Given this list of marker genes CIT, PEX5, ACD, MAT1A, NDUFS1, ADPRS, CHP1, LYRM4, KCNJ18, NR4A2, PITX3 (NCBI Gene Id 5309), ATP5MK, ALG3, MAGEL2, KIDINS220, CAPRIN1, TRMT10A (NCBI Gene Id 93587), FXN, FOXG1, WDR73, TMX2 (NCBI Gene Id 51075), TSEN2, AAAS, ERLIN2, NUP54, MYPN, SBF2, GBE1, NDUFAF2, ZFR, OCA2, H4C5, SLC18A2, TAF13, DYNC1I2, CASK, TSHR, TLR4, PET100, CCDC88A, DES, IFRD1, COQ4, MECR, PLEKHG5, SYNE2, TARDBP, PEX1, HSPB1, CYP27A1, LBR, SLC1A3, SDHAF1, ADGRG1, CNTNAP2, YARS1, YWHAG, KIF1B, LETM1, AIFM1, PPP1R15B, GTF2IRD2, LHX3 (NCBI Gene Id 8022), PRX (NCBI Gene Id 57716), CAMSAP1, GLRB, FTH1, LIMK1, POU1F1, GCSH, ERCC5, FANCM, REEP1 (receptor accessory protein 1), SLC20A2, NDUFS4, ABCC9, NFASC, PMPCA, PEX14, FANCF, MED25 (mediator complex subunit 25), MT-TT, GLYCTK, KBTBD13, STAT4, COQ7, GLRX5, XPC, TMCO1, HESX1, TRIM32, GDAP2, CHCHD2, CHCHD10, FUS, TMEM106B, GABRA2, LGI3, XRCC1, CHAT, SLC5A5, ACTA1, CAMTA1, CPT1C, PEX26, FBXL4, RMND1, CHRNB1, DNASE1L3, TBC1D23, GBA1, UBE3A, PEX19 (NCBI Gene Id 7835), OCRL (NCBI Gene Id 4952), BAZ1B, FA2H, DCTN1, SNUPN, COQ2, CSF1R, CEP63, TOE1 (NCBI Gene Id 80147), TMEM63A, VLDLR, KCNMA1 (potassium calcium-activated channel subfamily M alpha 1), PYROXD1, PLOD1, NAGLU, FXR1, MT-TE, CDK19, PNPLA2, ITGA7, ELN, RTEL1, HRAS, PARS2, COL4A1, SCYL1, NT5C2, HMGCL (3-hydroxy-3-methylglutaryl-CoA lyase), WASHC5, AP4B1, FLRT1, AGTPBP1, NSRP1, TCEAL1, ANG, BCKDK, ERCC3, EYA1, RNF113A, MINPP1, POU4F1, HCN1, STUB1, TIMM8A, ACER3, COX8A (NCBI Gene Id 1351), MT-TK, BICD2, SARS1, SDHA, CDK5, VPS13D, MYH14, SPTBN4, VCP, SLC25A12, NOP56, GPT2, ADCY5, SCN4A, ESAM, KY, CEP135, MT-ND2, FANCE, FBXO38, ENTPD1 (ectonucleoside triphosphate diphosphohydrolase 1), NEK1, SLX4, DYNC1H1, HYCC1, GTPBP2, KRAS, DNM2, RLIM, SNAPC4, PUS3, CNKSR2, CHRNE, PI4KA, NUP37, SLC12A2, PANK2, PKDCC, UBQLN2, DNAJC6, DNMT1, PRSS12, SPG11, DBH, LRP4, NIPA1, FGD4, JPH3, IRF2BPL, MBOAT7, SCN1A, GIPC1, CEP152, CHRND, MSTO1, RNF220, TTC19, LIFR, KDM5C, DYSF, HNRNPK, MYF6, INF2, VWA3B, XK, PSMC1, MAP3K20, PEX7, ATP1A3, RAB18, EXOSC8, TRIM37, CAMLG, ACTL6B, PIGQ, HSPG2, ALG1, DPYD, SNIP1, SIGMAR1, HTT, OPA1, EMILIN1, MRPS34, TRAPPC11, HLA-B, SNAP25, SLC52A3, TREM2, METTL5, DDC, SPTBN2, PDHB, NDUFAF4 (NADH:ubiquinone oxidoreductase complex assembly factor 4), SLC16A2, ANXA11, EXOC8, HEXB, COX6A1, ATXN3, CASP2, PIGA, ELOVL1, RAPSN, MSTN, PPOX, GNAO1, APOE, LMOD3, GTF2H5, HUWE1, TSEN34, COX11, SCYL2, DHTKD1, MYO1H, ALG11, ATG5, STAC3, TMEM43, LARGE1, SCN11A, RFT1, CNP, LGI4, BSND, PDGFRB, TTBK2, POMT2, OBSCN, ANKLE2, HSPD1, KCNB1, NONO, GLRA1, FKBP6, SV2A, PEX12, SPAST, CTSF, WWOX, TGM6, NDUFS8, ATP6AP2, PIGN, GFER, WDR4, PIEZO2, NECAP1, PROP1, REPS1, NDUFS2, APTX, SCN8A, MT-CO3, TRAPPC10, CREBBP, PEX16, NUP62, MDH2, GJA1, EEF2, VAMP1, PRICKLE1, SPEG, SLC39A8, GMPPB, GRM1, DKC1, DARS2, PIGB, HTRA2 (NCBI Gene Id 27429), AGRN, MFF, SPTLC1, FKBP10, AARS1, NRCAM, FASTKD2, SLC35A1, CCDC88C, CCR1, PRKN, UBAP1, SLC25A1, TSHB, FANCD2, FANCI, NADK2, CHKA, KCNA1, TBCK, MAB21L1, NFU1 (NCBI Gene Id 80767), HPDL, CCNF, SLC31A1, BRIP1, MAN2B1, GNS, COL6A1, FDX2, HECTD4, NEFL (neurofilament light chain), NDUFA4, DHX9, NCF1, BCAS3, METTL27, POLG2 (NCBI Gene Id 11232), KCNC2, ALDH5A1, MEFV, DNAJC30, CARS1, ERCC6, GNPTAB, HSPB8, DHDDS, PEX3, MPZ, SLC19A3, PDXK, RAI1, DHH, FBLN5, COX20, CLCNKA, RAB3GAP2, AP4M1, SLC6A19, LDB3, GNE, STIM1, PC, ABHD5 (abhydrolase domain containing 5, lysophosphatidic acid acyltransferase), SLC46A1, SNX14, RNASEH2C, MT-TW, STIL, PLEKHG4 (pleckstrin homology and RhoGEF domain containing G4), LRRK2, RNU4-2 (NCBI Gene Id 26836), NEUROG1, MORC2, VPS37D, VPS13C, AP3B2, LAMA2, KCNK4, GLE1, PAX1, ERBB4, NTRK2, SLC35C1, SLC33A1, TRAPPC6B, ERLIN1, ATP2A1 (NCBI Gene Id 487), PDE8B, TUBB2B, CDK5RAP2, NOTCH2NLC (notch 2 N-terminal like C), GRID2, SUMF1, SIL1, KCNQ3, PLCB1, NDE1, ITPR3, VAPB, STX1A, HSPB3, NARS1, HNRNPDL, FBN1, B4GALNT1, ARSI, TFG, LAMB2, WARS1, PTRH2, SH3TC2, FLII, PLP1, TPI1, REEP2, GEMIN5, AP4S1, DHX30, GRIN1, AMPD2 (NCBI Gene Id 271), ERBB3, NAA20, POU3F4, CARS2, GABRG2, MT-TL2, ANO10 (NCBI Gene Id 55129), SDHB, LMNA, MATR3, MCOLN1, IL12A-AS1, MCM3AP, HSD17B4, SOX10, KCNA2, PIK3R5, MYOT, MME, CLPB, PRDM13, TYROBP, IREB2, AP5Z1, CNBP, PARK7, INPP5E, KIAA0586, AASS, DST, CDK6, ZEB2, TPM2, NALCN, ASNS, ARHGEF2, TCAP, RAD51C, KATNB1, ZNF142, PGAP3, SLC1A4, EARS2, VPS13A, RFWD3, KLHL9, CAV1, CLP1, PMM2, IQSEC2, TAMM41, DDB2, HIBCH, DEGS1, SCN1B, FANCA, TTPA, TUBGCP2, TPP1, TAOK1, COQ9, SYNE1, ADCY6, ABCA1, ABCB7, SCN3A, HK1, KCNA4, TRAF3, KLC2, ELP2, CTNNA2, PITRM1, IL23R, CCT5, SASS6, SMN1, TTN, GPAA1, UGDH, BRAT1, SNCA, ATAD1, PUM1, SLC25A19, PSMB8, GRIN2D, PTF1A, XRCC2, LPIN1, ATRX, RETREG1, GAN (NCBI Gene Id 8139), RNF170, HADHB, GEMIN4, PHC1, TRIM2, PGAP2, SETX, VANGL1 (NCBI Gene Id 81839), PODXL, DDHD1, PALB2, ATXN1, SLC5A6, GNB1, PARN, TBL2, HDAC4, SIM1, GABRA3, MT-ND3 (NCBI Gene Id 4537), TUBB3, SLC25A22, SURF1, SPG7, B4GAT1, AR, BRCA2, GAD1, KDM1A, SNRPN, POMGNT1, HARS1, GLUL, TRIP4, TG, COLQ, PRKRA, PPIL1, TTR, DMXL2, ARSA, MICOS13, COX5A, POLR1A, DAG1, IFNGR1, KCNC3, NEFH, ALG9, DOK7, AUH, SET, PIGT, TECPR2, AP4E1, SYT2, ISCA1, PGAP1, IL10, FKRP, RUBCN, GLDC, NEU1 (NCBI Gene Id 4758), EP300, CACNA2D1, PLEC, PRORP, GFM2, TH, AUTS2 (activator of transcription and developmental regulator AUTS2), ERGIC1, ATP6V1A, PRPS1, MYL1, PEX13, GCH1, FAM111B, UBAC2 (NCBI Gene Id 94902), IMPDH2, DSTYK, TREX1, SHANK3, PLAA, COG4, RYR1, RARS2, GJB1, NUS1, HACD1, ALS2, MFSD2A, AMFR, EMC1, COASY, TPM3, ALDH18A1 (aldehyde dehydrogenase 18 family member A1), USP8, DKK1, KCND3 (potassium voltage-gated channel subfamily D member 3), SCN2A, MARS2, CRELD1, SNAP29, CRYAB, MT-TV, PLA2G6, JAG1, TCTN2, AK9, EBF3, GFAP, HTRA1, GLB1, EIF2AK2, BAG3, EIF4H, TOR1A, OPTN, MTTP, MCCC2 (methylcrotonyl-CoA carboxylase subunit 2), EXOSC5, KCNJ6 (NCBI Gene Id 8206), UROC1, TMEM63C, SLC38A3, PNPT1, SHMT2, GNAQ, PNKP, STX16, TUBA8, SLC25A4, CADM3, UFC1, UNC13A, GBF1, VPS37A, PRPH, ATN1, SLC13A5, NDRG1, CRAT, DDHD2, CHMP2B, PPARGC1A, DCAF8, PRUNE1, PIGV, SLC5A7, TRMU, AMACR, ST3GAL5, IER3IP1, CPT1A, CNTN1, FANCC, COX4I1, PPP2R5D, SLC18A3, TBC1D24, SLC29A3, FUCA1, EXOSC9, COA7 (cytochrome c oxidase assembly factor 7), L1CAM, PIGY, CLTRN, RPGRIP1L, TINF2, NDUFA1, PIGO, PON1 (NCBI Gene Id 5444), NEUROD2, ATM, BUD23, LYST, TBC1D20, SPG21 (NCBI Gene Id 51324), NRAS, DNAJC3, FIG4, ATXN2, SLC6A9, WDR62, NGLY1, HMBS, WDR81, PDGFB, MTM1, ABHD12, DALRD3, POLG, XPA, FGF13, GJC2, RARS1, GABBR2, PCDH12, CLDN11, ATP1A2, RRM1, MICU1 (mitochondrial calcium uptake 1), COG8, PIGL, GBA2, GAA, SPART, KIF14, ACO2, EIF2S3, PON3, PLAAT3, EEF1A2, SLC9A7, MED17, PYCR2, ASPM, ASCC1, GCLC, C4A, PRDM12, ZFYVE26, PRR12, BEAN1, SLC44A1, POLR3A, JAM3, NCAPD3, RAB7A, UBAP2L, RNF2, KCNQ2, QARS1, ATXN8OS, PTRHD1, NDP, DMD, DPM2, TRRAP, ST3GAL3, HIKESHI (heat shock protein nuclear import factor hikeshi), PAX7 (paired box 7), UQCRQ, FTL, KNL1, ATP9A, SLC52A2, TSEN15, ZC4H2, GTF2E2, ASAH1, MYO9A, RFX7, ALG6, TARS1, GGT1, HADHA, RILPL1, KCNT1, IGHMBP2, SQSTM1 (NCBI Gene Id 94002), JPH1, U2AF2, SMC5, RAP1GDS1, IBA57, GLT8D1, CLIP2, SELENOI, NAA10, TNR, TRMT5, SLC1A2 (NCBI Gene Id 6506), TICAM1, RRM2B, MECP2, PLXNA1, UBE2T, KPNA3, AP1S2, LRP12, ACADM, WDR45, DUOX2, CDC40, ADAR, FBXO7, GDAP1, MCM7, GNB4 (NCBI Gene Id 59345), CENPE, ALDH4A1, LRSAM1, MAG, MYH7, RNASEH1, TWNK, TK2, SELENON, PAH, EXOSC3 (exosome component 3), SLC2A1, DNM1, SMG9, CCDC47, ATXN7, TMEM270, HMGCR, TANGO2, NDUFAF3, SUCLG1, COQ5, IYD, FLI1, MT-TL1, ERCC2, PSEN1, FBXO28, GNB2, PQBP1, SZT2, DGUOK, LMNB1, CFL2, TRIO, DAO, MT-TN, UGP2 (NCBI Gene Id 7360), GARS1, ZIC2, SOD1, POLR3B, SPR, BCS1L (BCS1 homolog, ubiquinol-cytochrome c reductase complex chaperone), DTYMK, MUSK, TMEM240, SCN9A, PIGG, DUOXA2, OPA3, B3GALNT2, CD40LG, CACNA1B, SCN10A (sodium voltage-gated channel alpha subunit 10), FUZ, NFIX (nuclear factor I X), SLC9A1, TERT, NARS2, RFC1, UBA5, TBX4, ARL6IP1, CYP2U1, SLC12A6, CAV3, FRMPD4, ATP13A2, ATP5MC3, WLS, UNC93B1, CELF2, ERCC4, WARS2, FZR1, DPM1, MT-ATP6, DBR1, NEB, LHX4, VPS11, ELP1, NDUFA9, FKTN, QRICH1, GFM1, FLVCR1, AHDC1, ALG2, VRK1, ATP8A2, ENSG00000288330, RXYLT1, TSPYL1, ACAT1, TAF15 (NCBI Gene Id 8148), SYNJ1, KIF1A, PAK3, UCHL1, KIF5A, MEGF10, GALC, CLCNKB, ACSL4, SEMA6B, ADSL, COPB2, NUBPL, MRE11, MYL2, KLRC4, ABAT, TRAPPC14 (NCBI Gene Id 55262), SLC6A5, TNNT1, SMN2, CTDP1, SAR1B, MPV17, PHKA1, BSCL2, PEX11B, BIN1, GABRA5, ISCA2, COG7, PMP22, PPP3CA, SLC39A14, RFC2, SLC25A15, HNRNPA1, DYM, ATP1A1, SPTLC2, RTN2, PHKG1, PRRT2, ABCC8, KIF1C, CACNA1A, SEPSECS, SPTAN1, MKS1, PIGW, TAF1, TIMM50, ORAI1, NSUN2, GRIA3, SMPD1, COL12A1, EXOSC1, COG5, BRCA1 (NCBI Gene Id 672), PDK3, ERCC8, DENND5A, MFN2, SYNGAP1 (synaptic Ras GTPase activating protein 1), AMPD1, SUCLA2, ZNHIT3, KARS1, C19orf12, GOSR2, SACS, PTS, PPP2R2B, VPS33A, SAMD9L, RAB3GAP1, PDSS1, COL25A1, MAD2L2, FANCG, GRIN2A, NKX6-2, MPLKIP, GABRB2, OCLN, COL13A1, PIGP, GPHN, PGM3, COQ8A, ARX, FHL1, EGR2, POMT1, CD59, MT-CO1, GFPT1 (NCBI Gene Id 2673), ETHE1, ERAP1, PACS2, PI4K2A, PEX10, PEX2 (peroxisomal biogenesis factor 2), JAM2, GM2A, TRIM8, GOLGA2, TDP1, KCNK9, MSL3, ALG14, TMEM67, KCNE3, NDUFS7 (NCBI Gene Id 4727), DCC, CHRNA1, TBK1, MT-ND4, CACNA1G, PFN1, AFG3L2 (NCBI Gene Id 573970), UBA1, TPO, LRRK1, MLXIPL, SDHD, PPP1R21, SRPX2 (NCBI Gene Id 27286), SLC4A10, SLC32A1, MAPT, SBF1, TAF2, FLNC, CWF19L1, SEC31A, ATXN10 (ataxin 10), ITPR1, PRDM8, FGF12 (NCBI Gene Id 2257), DEAF1 (NCBI Gene Id 105376508), DARS1, IARS2, POMGNT2, SCO2, GAMT, GTF2I, VAC14, GRM7, RMRP, LYRM7, MT-ND5, TSPOAP1, CAPN1, PCYT2 (NCBI Gene Id 5833), ATL3, DHX16, ABHD16A, EXTL3, TBCD (NCBI Gene Id 6904), CFAP410 (NCBI Gene Id 755), RAD51, PCLO, WNK1, ATP2B3, OSTM1, ELOVL4, MTMR14, ABCD1, TLR3, HPRT1, TYMP, MCCC1, POMK, MTPAP, CRPPA, PMP2, MGME1, CA8, ZFHX3, DPAGT1, MTRFR, ATP7A, VWA1, PON2, DOCK3, TRAK1, MT-ND6, CC2D2A, ERCC1, FANCB, PHYH, AIMP2, GNAS (NCBI Gene Id 82944), SLC25A21, COX10, APOB, MYORG, FANCL, IL12A, ASPA, NAGA, KLHL41, MARS1, NUP214, ATP11A, LITAF, PEX6, MT-ATP8, PRNP, MCPH1, CACNA1E, GTF2IRD1, CACNA1S, BCAT2, PSAT1, CYFIP2, PET117 (NCBI Gene Id 100303755), DLAT, PRKCG, CHMP1A, SPTBN1, GRN, DNM1L, TSEN54, CDKL5, ATP6V1B2, SLC25A46, MRPS25, MMAA, SIK1 (NCBI Gene Id 54018), ZSWIM6, CLTC (NCBI Gene Id 9511), TRPV4 (NCBI Gene Id 8098), PINK1, RUSC2 (RUN and SH3 domain containing 2), PSAP, MT-ND1, SEPTIN9, PNPLA6, HINT1, CNTNAP1, ISCU, GMPPA, ACOX1, ADSS1, ATL1, AARS2, FAS, SLC2A3, FMR1, CYP7B1, EMD, PDYN (prodynorphin), NSD1, DNAJB2 (DnaJ heat shock protein family (Hsp40) member B2), FARS2, DPM3, here is a description of the gene set: Any anomaly of a reflex, i.e., of an automatic response mediated by the nervous system (a reflex does not need the intervention of conscious thought to occur). species: Homo sapiens Abnormal reflex Human Gene Set: HP_ABNORMAL_REFLEX